The following is a description of a gene set: studied in species Homo sapiens The Influenza Virus NS1 protein inhibits the cleavage and polyadenylation specificity factor CPSF and the PABII components of the host cell 3' end processing machinery, preventing efficient 3' end processing of host pre-mRNAs. NS1 also inhibits the splicing of pre-mRNAs, resulting in their retention within the host cell nucleus. Reactome Pathway: Inhibition of Host mRNA Processing and RNA Silencing part of: NS1 Mediated Effects on Host Pathways, and this is the list of marker genes: PABPN1, NS, CPSF4 (NCBI Gene Id 10898)